Given this list of marker genes Nrp2 (neuropilin 2), Six4, Ctnnb1, Six1, Sema3a, Nrp1, here is a description of the gene set: Mouse Gene Set: GOBP_CRANIAL_GANGLION_DEVELOPMENT The process whose specific outcome is the progression of a cranial ganglion over time, from its formation to the mature structure. studied in species Mus musculus